Given this list of marker genes AMY2A, AMY1B, AMY1C, AMY2B, AMY1A, here is a description of the gene set: species: Homo sapiens Catalysis of the endohydrolysis of (1->4)-alpha-D-glucosidic linkages in polysaccharides containing three or more alpha-(1->4)-linked D-glucose units. Human Gene Set: GOMF_ALPHA_AMYLASE_ACTIVITY